Given this list of marker genes Usp18, Ifna15, Ifnb1, Ifna11, Ifna1, Ptpn1, Ptpn6, Ifna6, Ifna4, Ifnar2, Ifna2, Ifnab, Ifna7, Ifna12, Ifna9, Ifna14, Ifna16, Ifna5, Stat2, Ifna13, Ptpn11 (NCBI Gene Id 72646), Tyk2, Ifnar1, here is a description of the gene set: Mouse Gene Set: REACTOME_REGULATION_OF_IFNA_IFNB_SIGNALING Regulation of IFNA/IFNB signaling studied in species Mus musculus